Given this list of marker genes UCP2, KCNJ11, CAV1, CIDEC, HADH, SLC25A36, HNF1A, CAVIN1, PPARG, BSCL2, AGPAT2, FOS (Fos proto-oncogene, AP-1 transcription factor subunit), INSR, ABCC8, here is a description of the gene set: Human Gene Set: HP_INCREASED_C_PEPTIDE_LEVEL An elevated concentration of C-peptide in the circulation. Since C-peptide is secreted in equimolar amounts to insulin, this feature correlates with increased insulin secretion. species: Homo sapiens Increased C-peptide level